Given this list of marker genes Fgfr1, Fgf20 (NCBI Gene Id 80857), Fgf2, Fgf8, Fgf1, Fgf10, Frs2, Hras, Fgf23, Fgf17, Fgf22, Grb2, Fgf4 (NCBI Gene Id 14175), Fgf6, Fgf5, Kl, here is a description of the gene set: Reactome Pathway: FRS-mediated FGFR1 signaling part of: Downstream signaling of activated FGFR1 studied in species Mus musculus electronically inferred by orthology from the curated human pathway This event has been computationally inferred from an event that has been demonstrated in another species.<p>The inference is based on the homology mapping from PANTHER. Briefly, reactions for which all involved PhysicalEntities (in input, output and catalyst) have a mapped orthologue/paralogue (for complexes at least 75% of components must have a mapping) are inferred to the other species.